The following is a description of a gene set: Human Gene Set: HE_LIM_SUN_FETAL_LUNG_C0_LATE_MESOTHELIAL_CELL Late mesothelial species: Homo sapiens from publication He P, Lim K, Sun D, Pett JP, Jeng Q, Polanski K, Dong Z, Bolt L, Richardson L, Mamanova L, Dabrowska M, Wilbrey-Clark A, Madissoon E, Tuong ZK, Dann E, Suo C, Goh I, Yoshida M, Nikolić MZ, Janes SM, He X, Barker RA, Teichmann SA, Marioni JC, Meyer KB, Rawlins EL (PMID 36493756), and this is the list of marker genes: SP100, PHLPP2, IFI27, SERPINB1, TNFAIP8L3, TMTC2, NMU, TOB1, SERPINB9, KRT18, BCAR3, DHCR7, MMP28 (NCBI Gene Id 79148), MT1E, TRADD (TNFRSF1A associated via death domain), UBXN6, ZDHHC24, PGF (placental growth factor), ERRFI1, OCIAD2, COL2A1, PCK1, C1RL, NPDC1, C4B, IRF7, PSMB8, NMI, ARHGAP29, SLC25A23 (NCBI Gene Id 79085), WDTC1, GKAP1, USP25, NXPH2, FXYD5, FLRT3, CD74, HSBP1L1, HAGH, CGN, PDZK1IP1, SH3GLB2, DHRS12, RAPGEF3, CDCP1 (NCBI Gene Id 64866), SIRT5, ABHD5, TMEM106C, SORBS2 (sorbin and SH3 domain containing 2), LAMA3, PLAAT4 (NCBI Gene Id 5920), HTRA1, NELL2, CTXN1, HDAC7, MT1X, CAPG (capping actin protein, gelsolin like), DLG5, HRCT1, ICAM1, MAL2, DVL1, CCDC74A, DNAJC25, PLAAT3, EVA1C, OBSL1, RSPO1, IL18, CALML4, CSDC2, IL6, LEPROTL1, MISP, SCARB1, GALNT9, SDC4, TVP23A, ANXA3, TNXB, CRIM1, NPAS2, P4HA2, IL10RB, OPTN, ARHGEF5, PLLP, NRG4, KIF1C, NDST3, HAGHL, IGFBP6, CLIC5 (NCBI Gene Id 53405), SH3BP4, DPP7, FN3K, STRADB, NCOA7, SEZ6L2, SH2D4A, KRT5, PSMB9, P4HTM, EPCIP, TBC1D22A, ANXA9, COL18A1, PLEKHA4, NCAM2, TMEM176A, MAP3K11 (NCBI Gene Id 4296), AJM1, RAB11FIP1, LSR, ZDHHC12, ARPC1B, RETREG1, LIMS2, A1BG, RBM47, MX1, AQP3, ITM2A (NCBI Gene Id 9452), CCDC85C, POMGNT2 (protein O-linked mannose N-acetylglucosaminyltransferase 2 (beta 1,4-)), PDPN, TSPAN18 (tetraspanin 18), SLC34A2, PPP1R13L, ZNF579, C1QTNF1, PEG3, METTL25, RNLS, ARHGAP18, IGHG4 (immunoglobulin heavy constant gamma 4 (G4m marker)), SMTNL2 (smoothelin like 2), ITLN1, MMEL1, SLC48A1, SMPD3, FGF18, CYSTM1, TRIB1, CAVIN2, RIC3, RPRM, PLEC, LINC02381, ACTC1, PTAFR (platelet activating factor receptor), NR4A1, CRLS1, HSPA12A, SLC25A4, UAP1, PNPLA2, RABGGTA, ST3GAL5, ITPR2, TPD52, MST1, DRC12, SLC22A18, CYBC1, CMYA5, ANXA1, ADAM15, ASS1, DOK7, THSD4, CLDN1, SYNGR2, PBX3, DECR2, TGFB3, INMT, TBX18, COL8A2, JOSD1, UPK1B, SMOC2, PIEZO1, STK26, PLAUR, GSDME, EFNB3, SVIP, PKP2, DPYD, TNFAIP3, GCHFR, CA2, GFPT2, AMOTL2, WT1, SMPDL3B (sphingomyelin phosphodiesterase acid like 3B), SCEL, KCNT2, GATA4, PODXL, FAM221A, NAAA, RHOD, LRATD2 (NCBI Gene Id 157638), SBSPON, LAMC2, LIME1 (NCBI Gene Id 54923), PODN, AHNAK2, ARL8A, SLC16A1, PRKCZ, IFITM1, BTC, SLCO3A1, AVPI1, NHERF4, ETHE1, HSPB8, GRB7, NSG1, COBL, PLA2G2A, RGP1, LINC01133 (NCBI Gene Id 100509784), SHTN1, CCDC74B, CA9, HAS1, PRR15, CDK2AP2, NCOR2, SPOCK2, DDR1, TCAIM, TTLL5, KRT8 (NCBI Gene Id 90177), TMCO3, BOK, SPRR2F, LAMA5, CD55, SLC7A7, DSG2 (desmoglein 2), SHROOM3, DBP, SEPTIN1, ATP7A, RBP7, RAET1E, MIF4GD, DPP4, BCO2, ST6GAL1, TAPBP, NTNG1, VAMP8, C4A, RALGDS, FUCA1 (NCBI Gene Id 2517), C1orf53, NINJ1, PLXNB1, PTPN14, EFNA1, GBP3, SOX6, PTPRF, TAP1, AGRN, ANXA8L1, UNC5B-AS1, MAP3K3, WWC1, AQP1, FOSL2, EPS8L2, PTGS1, RAB7B, NUDT14, SRSF8, VEGFB, STAP2, LINC01638, PDGFA, ALOX15, GPM6A, CFI, CYP4B1, FRY, SIRPA, CRIP1, SLC39A8, APLP1, CLCF1, FRAS1, FGFRL1, VIPR2, DSC2, PTGIS, SYCE1L, ASPHD1, ANG (angiogenin), TMEM151A, REEP1, PLP2, WWC2, PDE1A, LIAT1, PALM, KLK10, LY6H, EML3, FNDC1, PDXK, PTPRQ, NDRG1, RSPO3, RAB29, FABP3, DHCR24, MAP3K8, RERG, SCG5, CALHM6, BCL3, PYGL, DOCK11, MTHFS, FAM3B, SULF1, SEMA6A (NCBI Gene Id 57556), LMO7 (NCBI Gene Id 4008), PBXIP1, ANOS1, PLEKHA1, EMP1, FENDRR, GCA (NCBI Gene Id 25801), SPINT2, SPACA9, CTSD, EPS8, NQO1, RNASE1, BAIAP2, TPRN, TMEM191B, GOLM2, IDS, IL16, ADARB1, PHYHIP, MGAT4B, GAS6, CXADR, ZBTB7C, HEG1, NHSL3, KLK1, CDC42EP3, CDON, MYEF2, FBXL2, ADAM33, SMIM11, SLPI, NEDD4L, GALE, DUSP23, PCOLCE2, VWA5A, MKNK2, MAG, CFAP68, FZD6, EPHB6, PUSL1, ADAMTS5, PARP9, ZC3HAV1, CCDC51, GADL1, PLCB1, EFEMP1, COL11A1, PTPRE, CFC1, KLK11, CTSE, PIM3, PALS2, MRGPRF, ATL1, NHSL1, COL9A3, CLIC3, ANKH, TMEM37, TMEM8B, GSDMD, TBC1D10A, ARL4A, TMEM9B, ARRDC4, ANXA8, ADAMTS3 (NCBI Gene Id 9508), TMEM88, CD47, PKHD1L1, APOL1, CPLX1, ARRDC1, SPTLC2, TOR1AIP2, CDH3, MAFF, IL17RE, OSTM1, TM7SF2, LTC4S, CCNDBP1, CFB, RASSF8, C1GALT1, ZNF467, ITPK1, SPECC1, CHRDL1, WFDC2, GABARAPL1, OSCP1, DAG1, GJA1, ABHD12B, ITPR3, MGLL, AP1G2, LRRTM1, PDGFRL (platelet derived growth factor receptor like), PYCARD, VSIR, MSLN, MBP, ALCAM, TM4SF1, HSPG2, PDLIM5, ARHGAP22, LRRN1, PDZRN4, HLA-DQB1, SH3BP5, ATF7IP2, MTHFR, BCR, BMP3, FYB2, ITGB8, DHRS3, PAWR, PRELP, TNFSF13, RFK, STK24, ENTPD2, EIF1AY, SPINT1, CD320, LRRN4, HPGD, CLIP4, LGALS2, MCUB, KIF21A, BHLHE40, GPNMB, CA11, CAMK1D, TSTD1, EPB42, FGF9, COL4A6, FAAH, MET (NCBI Gene Id 4233), NPR1, PCLO, SEC11C, LRP11, GLP2R, PPP1R16A, NFATC2, BNC1, ROM1, METTL21A, PITPNC1, IL13RA1, TST, MANSC1, TNNT1, LPAR5, TNNT2, COMTD1, GALNT18, FSTL3, ITGA6, NET1, IER5, CCPG1, KLF9, SLC26A2, GATA6-AS1, CSRNP1, MYO1E, BDNF, CIC, CGNL1, CLEC16A, PAK4, CFH, CLSTN3, PRR15L, CARD16, KANK1, RRAS, APOL2, KLF2, ADAMTSL4, STX11, CDKN1A, GPRC5A (NCBI Gene Id 9052), LY6G6C, NADSYN1, TCEAL2 (transcription elongation factor A like 2), A4GALT, BDKRB1, CTSH, MAMSTR, DMKN, SPOCK1, MN1, GLS, RGS10, TOM1L1, MYO1D, SOX15 (SRY-box transcription factor 15), CRACR2B, PPL, KDELR3, TFPI2, CRELD1, ARHGAP23, BCAT2, MCRIP2, TGFBR2, KLF5, REC8, GLIS2 (GLIS family zinc finger 2), UCHL1, CD9, IQCA1, MAPKAP1, ABHD17A, TRAF5, MIEN1 (NCBI Gene Id 84299), VPS13A, RNASE4, C19orf33 (NCBI Gene Id 90521), EEIG1, GEM, CARNS1, AXL, MYRF, TPBG, NIPAL3, AGA, FLNB, KRT7, PLEKHF1, RHPN2, GSG1L, IFI35, TGM1, CAV2, ANKRD29, FCMR, RAB33A, FKBP11, PLCD3, AGAP3, BICDL1, HLA-DRB1, FBXO2, ALDH1A2, PTDSS2, PARD6B, CNTNAP3B, AOX1, MLPH, PDZD2, CPNE2, CYP27A1, KRT19, TMEM176B, PNOC, PERP, MDGA1, BNC2 (basonuclin zinc finger protein 2), ADGRD1 (NCBI Gene Id 283383), KRTCAP3, NAV2, IGFBP2, YDJC, FLRT2, WNT2B, CASP4, SMIM1, EFNB2, FAM107B, CFC1B, HHIP, PDGFC, PLEKHG3, SEMA3B, SEMA3C (semaphorin 3C), MT1M, LINC01018, AMHR2, FAM174C, TBC1D2B, FAM110C, PRG4, MYO5B, CSF1, UBE2D4, RASSF7, CCDC186, ERAP1, UBE2Q1, PARD3B, EMILIN2, SFRP5, B9D1, NRBP2, TRNP1, DBNDD2, ADIRF, CYP4X1, COBLL1 (cordon-bleu WH2 repeat protein like 1), CCN4, C1R, EPS8L1, LINC00842, HHIP-AS1, SERTAD4-AS1, NACC2, BST1, UPK3B, GIT1, TCEA3, IL6R, CADPS2, LIF, SLC16A3, GOLGA8B, CLDN15, RILPL2, MVP, LHPP, ANKRD13B, APOL4, ALDH3B1, GAS1, RPRD1B, ECHDC2, IGSF9, CTNNA3, DSC3, TSPAN7, CST6, TLL1, MTUS1 (microtubule associated scaffold protein 1), PROCR, C3, CXCL16, MIB2, CCND3, MEDAG, SLC7A4, NPNT, SLC38A1, TMEM132A, MEGF6, SLC25A29, SSH3, PROS1, RDH10, FMO1, LGALS8 (galectin 8), BEX2, ITGA3, MUS81, PDLIM4